The following is a description of a gene set: Mouse Gene Set: GOMF_MEDIUM_CHAIN_FATTY_ACID_COA_LIGASE_ACTIVITY species: Mus musculus Catalysis of the reaction: a medium-chain fatty acid + ATP + CoA = a medium-chain fatty acyl-CoA + AMP + diphosphate. A medium-chain fatty acid has an aliphatic tail containing 6 to 12 carbons., and this is the list of marker genes: Acsl3, Acsm3, Acss3, Acsm1 (acyl-CoA synthetase medium-chain family member 1), Acsm4, Acsm5, Acsm2, Aacs, Acsf2